The following is a description of a gene set: Neighborhood of DAP3 death associated protein 3 in the MORF expression compendium studied in species Homo sapiens Human Gene Set: MORF_DAP3 Neighborhood of DAP3, and this is the list of marker genes: EIF3I, ALG3, SRSF9 (serine and arginine rich splicing factor 9), EIF2B5, HNRNPAB, PSMB3, SDHA, UBE2L3, DYNLL1, XPO7, NCBP2 (nuclear cap binding protein subunit 2), JTB (jumping translocation breakpoint), MRPL9, ZNF146, ANAPC5, HNRNPUL1, DDX39B, SSR2, IK, STARD7, AFG3L2, LSM2, COX7A2L, SNRPB, DDB1, HSPD1, PSMD2, COX8A, ATP5MF, PARK7, PSMB7, NONO, BAG6, ZPR1, SLC30A9, VDAC2, AP2M1, KXD1, METAP1, EPRS1, GANAB, ZNHIT3, UBA1, POP5, EIF3M, DDT, COX5B, PPP1R11, EBP, NELFB, ATXN10, CCT3, HNRNPA2B1, ARPC5 (actin related protein 2/3 complex subunit 5), RPN2, DAP3, NIPSNAP2, PIGC, AHCYL1, ARFGAP2, BUB3, CALM2, PSMB6, DDX49, SET, ILF2 (NCBI Gene Id 3608), PSMD8, LYPLA1, CCT2, EIF4A2, PPP2R1A (protein phosphatase 2 scaffold subunit Aalpha), HAX1, IDH3B, YWHAZ, COX6B1, NDUFV1, NCL, HSP90AB1, MDH1, PPP1R7, CNBP, COX7C, STOML2, NAP1L4, RUVBL2, ATP6V1F, YWHAB, CS, CLNS1A, SLC25A3, SEC61B, CBX3, CTBP1, RAN, DRG1, NDUFB5, PGK1, EIF2B4, FIBP, XPO1, XRCC5 (X-ray repair cross complementing 5), PDHB, LRPPRC, COPS6, UQCRB, TRAPPC3, CAPZB, DGUOK, TIAL1, PHB2, SLC25A5, SRP14, UQCRH, NUP188, SNRPA, PSMB4, TCEA1, HADHB, KHDRBS1, SMNDC1, PIN1, MARCHF7, BRD8, RPP40, HUWE1, POLR2H, ZC3H15, YWHAQ, GATD3, DDOST, RALY, CCT7, PSMB1, SMARCC2, TBL3, MRPL23, COX4I1, FAM120A, GDI2, COX6A1, KARS1, SUMO1, CANX, GPAA1, FBXW11, SP3 (Sp3 transcription factor), DEK (DEK proto-oncogene), SDR39U1, POLR2I, EIF3K, DNPEP (aspartyl aminopeptidase), TBCB, TUFM, SNRNP200, SERP1, NDUFS3 (NCBI Gene Id 4722), PSMB2, CYC1, NRDC, DNAJC8, NIPSNAP1, FDPS, SARS1, SUMO2, OXA1L, SNRPE, SRP9, ACLY, TMEM147, HSPA8, AATF, BANF1, EIF6, COPS5, CTDNEP1, UBE2I, PUF60, BRD3, PRKAR1A, EIF1AX (eukaryotic translation initiation factor 1A X-linked), CSNK2B, SPCS2, ATP5MC3, PRKAG1 (protein kinase AMP-activated non-catalytic subunit gamma 1), RTCB, IMPDH1, GPN1, COX7B, SETD3, PDAP1, VGLL4, HNRNPC, PUM2, CAPZA1, RHEB